The following is a description of a gene set: Reactome Pathway: Pervasive developmental disorders part of: Disorders of Nervous System Development species: Homo sapiens Pervasive developmental disorders (PDDs) largely overlap with the autism spectrum disorders (ASDs). PDDs manifest in childhood and mainly affect social interaction, including communication and behavior. PDDs can be caused by mutations in genes involved in brain development and function, environmental insults, or the combination of environmental factors and genetic susceptibility. For review of this topic, please refer to Picket and London 2005, Currenti 2010, Elsabbagh et al. 2012, Ferreri 2014., and this is the list of marker genes: TBL1X, NCOR1, PRKACA (protein kinase cAMP-activated catalytic subunit alpha), SIN3A, HDAC3, CALM1, HDAC1 (histone deacetylase 1), BDNF, MECP2, GPS2, TBL1XR1, NCOR2, CAMK4